The following is a description of a gene set: Stereotypical body rocking Human Gene Set: HP_STEREOTYPICAL_BODY_ROCKING Habitual repetitive movement of the entire body, front to back or side to side. studied in species Homo sapiens, and this is the list of marker genes: ZSWIM6, DPAGT1, AFF2, YME1L1, NEXMIF, WDR26, GNB2, KIF15